Given this list of marker genes CISH, LAP3, CCL17, CRIP1, EEF1G, UNC119, SH3BP1, PLCB2 (phospholipase C beta 2), UCK2, PNPO, STAP2, IQGAP2, KCNK13, RAMP1, SMC6, GUK1, ATP5MC2, DAGLB, TF, CD93, RPS25, CDK4, PTPRO, NME1, P2RY12, HAUS4, AIMP2, KLF4, PPP1R14B, PYCARD, OCSTAMP, ABCD2, RGS14, GMNN, NFE2, PYGL, MICAL1, CENPT, ST6GALNAC4, CCDC80, VPS37B, UQCRQ, VDR, TEC, FANCA, COMT, BACH1, ETFB, RNASE4, ATG3, CA4 (carbonic anhydrase 4), TYROBP, PALD1, RNF166, MRPL23, SEPTIN6 (NCBI Gene Id 23157), ACAT1, CCR2, TAF10, HACD4, RASSF5, GNB4, CCN3, OSGEP, MYL12B, TSPAN4, CDKN1A, UBL4A, ALDH9A1, SIDT2, MCUB, ITGA6, C1QTNF12, LPIN1 (lipin 1), SDF2L1 (stromal cell derived factor 2 like 1), TIMM8A (translocase of inner mitochondrial membrane 8A), TNFRSF1A, ARL2, RYR1, RIPK3, TEX264, OXCT1, VWF, RPS19, BATF3, PPP1R21, RNASE2, HMBS, NANS (N-acetylneuraminate synthase), HSD17B4, NAAA, GPX3, SMYD2 (SET and MYND domain containing 2), S100A9 (S100 calcium binding protein A9), C1QBP, EPS8, SLC35C2, CHMP4B, CEACAM21, TIMP2, TBATA, MT1E, ETHE1 (ETHE1 persulfide dioxygenase), CENPA, HLA-DMA, CBFA2T3, CIITA, APRT, CMTM3, DEPTOR, RRAS2, SCML4, ACY1, EBP, ABCD1, LGALS1, ALDOC, RAB7A, GPR35, CD300A, MRPS23, GFRA3, DOLPP1, ZFYVE19, MRC1, ZFP36L1, HAUS8, MTSS1, PPARGC1B, ZNF706, ARG1, ALDH1A2, SPINT1, PPP4R1, TMEM37, SNX20 (NCBI Gene Id 124460), PLGRKT, DOK2, CD300LF, RGS2, TNS1, ODC1, ZNF703, HLX, ZFYVE21, RAB3IL1, CLEC7A, MYCBP2 (NCBI Gene Id 55685), NDUFA12, THYN1, CCNH, ASB4, QPCT, ITGB7, SPTSSA, S100A6, TXN2, ZYX, SPP1, RNF187 (ring finger protein 187), GYG1, ADGRE5, PTGS1, MICOS13, EZR, NDUFS3, RMND5B (required for meiotic nuclear division 5 homolog B), S100A11, PDCD6, CLEC10A, SOX4, TXNIP, GCNT1, FKBP2, JARID2, RPS6KA3, NDUFS8, IRAG2, NDUFB10, PLXDC2, B3GNT5, NSDHL, ACAA2, IL11RA, NFIX, CHCHD10, GLUL, POLE3, PDCD1LG2, SSBP2, UQCR11, MRTO4, CD6, GNA15, GNL3, NQO2, SLC25A15, PGP, HEMK1, SEPTIN4, here is a description of the gene set: Human Gene Set: GSE17721_0.5H_VS_24H_CPG_BMDC_UP Genes up-regulated in comparison of dendritic cells (DC) stimulated with CpG DNA (TLR9 agonist) at 0.5 h versus those stimulated with CpG DNA (TLR9 agonist) at 24 h. mouse primary BMDCs were stimulated with tlr ligands and gene expression changes were profiled on Affymetrix arrays from publication Amit I, Garber M, Chevrier N, Leite AP, Donner Y, Eisenhaure T, Guttman M, Grenier JK, Li W, Zuk O, Schubert LA, Birditt B, Shay T, Goren A, Zhang X, Smith Z, Deering R, McDonald RC, Cabili M, Bernstein BE, Rinn JL, Meissner A, Root DE, Hacohen N, Regev A (PMID 19729616) studied in species Homo sapiens